Given this list of marker genes Plekhm2, Dysf, Rab14 (RAB14, member RAS oncogene family), Vamp9, Vps39, Coro1a, Yipf5, Cacna1b, Rufy1, Vti1a, Bloc1s6, Chmp1a, Erc2, Septin8, Pikfyve (NCBI Gene Id 71407), Znrf1, Rubcnl, Vti1b (vesicle transport through interaction with t-SNAREs 1B), Tgfbrap1, Grik5, Vamp3, Rab4b, AU040320, Nkd2, Syt1, Stxbp6 (NCBI Gene Id 97823), Cplane2, Anxa1, Syt9, Eea1, Anxa2, Vps41, Cplx1, Stx3, Chmp2a, Stx19, Chmp4b, Cltrn, Sphk1, Stxbp1 (NCBI Gene Id 98927), Stx8, Pip4k2a, Vamp1, Rph3al, Chmp1b, Syt8, Sec22b, Cav2, Chp1, Chmp4c, Tom1, Yipf7, Stx5a, Rab7, Chmp2b, Rufy4, Slamf1, Ankrd27, Stx17, Pla2g5, Vps8 (VPS8 CORVET complex subunit), Spg11, Snap25, Stx2, Rab3a, Yipf4, Stx16, Vps4a, Snap47, Stx7, Rims1, Uvrag, Chmp5, Tmem175, Trim9, Stx6, Vav3, Plekhm1 (pleckstrin homology domain containing, family M (with RUN domain) member 1), Chmp3, Stx1b, Diaph3, Syt3, Stx4a, Chmp6, Uso1, Syt2, Rims2, Znrf2, Tbc1d4, Bet1, Rph3a, Vamp4, Snap29, Vamp2, Rab8a, Doc2g, Vamp8, Syt5, Snap23, Ankfy1, Cln3, Rab20, Syt13, Doc2a, Snca, Syt4, Stx12 (syntaxin 12), Cplx4, Rimbp2, Snph, Kif5b, Rab7b, Samd9l, Stx1a, Erc1, Atp13a2, Snapin, Bnip1, Prrt2, Stx11 (syntaxin 11), Sox30, Syt7, Chmp1b2, Cplx2, Rab34, Rab39, Gosr2, Vps11, Syt11, Pla2g4a, Doc2b, Cplx3, Gnai3, Chmp7, Arl8b, Pip4k2b, Vcpip1, Gosr1, Trarg1, C2cd5, here is a description of the gene set: The joining of two lipid bilayers to form a single organelle membrane. species: Mus musculus Mouse Gene Set: GOBP_ORGANELLE_MEMBRANE_FUSION